The following is a description of a gene set: Sclerosis (increased density) affecting vertebral end plates. studied in species Homo sapiens Human Gene Set: HP_SCLEROTIC_VERTEBRAL_ENDPLATES Sclerotic vertebral endplates, and this is the list of marker genes: ENPP1, CLCN7, CCN6, LRRK1, SOST, DMP1